Given this list of marker genes GPATCH2L, ASXL1 (NCBI Gene Id 23393), FOXB1, DIABLO, PI4K2A, AKT2, PLA2G5, NDRG1, PEF1, H3C7, ATP5MC1, FZD4, CORO1B (NCBI Gene Id 57175), CFHR4, EPB41, OLFML3, MAGIX, BCAN, MIA3, LONRF3, SYNGR2, ATP8B3, GLP1R, RNF185, GABRA4, PANK4, CSDC2, RGS9, CES1, GRIA1, CRK, SCN1B, CA4, FGF9, TAOK2, TP53I11, HHAT, FGA, CNGB3, PHKA1, RTEL1, AR, NR6A1, RALGAPA1, SYDE1, GSTT1 (glutathione S-transferase theta 1), KIR2DL1, KIAA0586 (NCBI Gene Id 9786), NHERF4, SCARF1, EYA2, SLC22A6, STX4, LRRC61 (leucine rich repeat containing 61), ARHGAP24, PSME4, GARS1, RGL2, POLD4, PRKCD, NAPA, ASPM, RHEB, CELF1, ITIH3, TNNI1, MARCKSL1, STK19, ANKHD1, ETNK2, RALGDS, RIBC2, CSTF1, CAMKK2, ITGA8, MYLIP, RBFA, ARSF, CALR, TRIM25, ELN, IL1A, OXLD1, MMACHC, ARPIN, RPL35, CYP4F12, CDC7, AKT1 (AKT serine/threonine kinase 1), PHAF1, PRKAR2B, CSNK1D, CALY, IST1, SLC6A8, CCNL2, ERMP1, H2BC13, ABHD8, CTPS2, SPMAP2, BCL7C, PRDM14, SEC24C, ZNF512B, SLC2A6, ZNF133, GPD1, PRF1, ABCF1, GRAP, CHRM5, CIDEC, NOMO3, TCF7, ELL2, FRS2 (NCBI Gene Id 10818), NCOR2, PDE6B, TTC3, PLA2G2F, VPS50, SLC9A1, MAMLD1, ORAI2, FARP1 (FERM, ARH/RhoGEF and pleckstrin domain protein 1), IFNGR2, PGC, EFNA2, CDC37, ZNF778, PCYOX1, NME5, PLEKHJ1, ABCD1, KIF5A (kinesin family member 5A), IBTK, ING3 (NCBI Gene Id 54556), PRKD3, DARS2, DUSP5, HSPB8, SH3GL1, AKAP8L, CD82, CLCA4, SMTN, HS3ST3A1, PKDREJ, KRT81, SCN8A, SERINC3, TNFRSF9, LAMB3, ZER1, ACSBG1, ZNF365, AHSG, PSG3, FBXO31, SPAG7, C1orf54, REG1A, EHMT2, ZNF157, IRX5, CD248, MAFF, CD79A, LAMP5 (NCBI Gene Id 24141), BSG, AMPD2, COPS6, KCNJ6, MYOM1, SH3D21, C3, CD74, NDUFV2, PPP6R2, TUBB, PKP3, DCAF15, WRAP53, TCF25, CDX4, NTSR2, PPP1R16B (protein phosphatase 1 regulatory subunit 16B), CHGA, PDGFRB, CADM3, MRPL12, GOLGB1, ELOA, FUBP1, AMDHD2, POLR1G, THAP9, here is a description of the gene set: species: Homo sapiens from publication Jeffrey KL, Brummer T, Rolph MS, Liu SM, Callejas NA, Grumont RJ, Gillieron C, Mackay F, Grey S, Camps M, Rommel C, Gerondakis SD, Mackay CR (PMID 16474395) Genes down-regulated in comparison of untreated neutrophils versus neutrophils treated with LPS (TLR4 agonist) at 1 h. Human Gene Set: GSE3982_CTRL_VS_LPS_1H_NEUTROPHIL_DN In the present study we used Affymetrix oligonucleotide microarrays to produce gene transcription profiles for the major leukocyte types in humans. This comprehensive dataset enabled us to not only establish which genes were expressed in each leukocyte type, but also which genes were expressed in each subset after activation. The used of a comprehensive dataset of gene profiles from all the major human leukocyte subsets enabled a novel and powerful means for identification of genes associated with single leukocyte subsets, or different immune paradigms.